The following is a description of a gene set: Any process that stops, prevents or reduces the frequency, rate or extent of cGAS/STING signaling pathway. species: Homo sapiens Human Gene Set: GOBP_NEGATIVE_REGULATION_OF_CGAS_STING_SIGNALING_PATHWAY, and this is the list of marker genes: PCBP2, AKT1, TREX1, BANF1, ZDHHC18, IRGM, PPP6C, PRKDC, PARP1, SPSB3, AARS2, CGAS, MIR4691, SMPDL3A, LYPLAL1, AURKB